Given this list of marker genes NF2, PIK3CA, COCH, KRIT1, CCM2, DKK1, PDCD10, COQ6, LZTR1, HRAS, KARS1, SMARCB1, SPRED1, here is a description of the gene set: studied in species Homo sapiens Human Gene Set: HP_ABNORMAL_VESTIBULOCOCHLEAR_NERVE_MORPHOLOGY Abnormal vestibulocochlear nerve morphology Any structural anomaly of the vestibulocochlear nerve. The vestibulocochlear nerve consists of the vestibular and cochlear nerves, also known as cranial nerve eight (CN VIII). Each nerve has distinct nuclei within the brainstem. The vestibular nerve is primarily responsible for maintaining body balance and eye movements, while the cochlear nerve is responsible for hearing.